Given this list of marker genes KAT2B, TFF3, SERPINA12, GCG, GNB3, SIK1, AKT2, PTPN2, AKT1, PPP4R3B, LEP, PDK3, IRS2, ZFP92, IRS1, ZNF692 (NCBI Gene Id 55657), IGF2, SESN2, TP53, KAT2A, ACADM, PPP1R3B, PGP, PRKACA, LEPR, RANBP2, NR0B1, MTCL2, MST1, SLC35B4, SIRT7, PPP4R3A, ZMPSTE24, SLC45A3, PMAIP1, LCMT1, FOXK1 (NCBI Gene Id 650798), PPP1R3G, ADIPOR1, RORC, INS, PRKAG2, USP7 (NCBI Gene Id 7874), CRY1, SORBS1, EP300, MIR107, PRKN, PTH, FOXO1, BCKDK, FBP1, C1QTNF3, PPARA, DDB1, ACACB, EPM2AIP1, PHKG2, FOXK2, MIR103A1, CLK2, GCK, SIRT1, NNMT, DYRK2, C1QTNF12, NLN, DGAT2, ADIPOQ, OGT, TCF7L2, MLYCD, PDK2, ADCY10, MIR210, IGF1, PPARGC1A, INSR, SDHAF3, NCOA2, GNMT, PRKAG1, PPP1R3E, PDK4, GPLD1, RORA, ARPP19, C1QTNF1, SIRT6, ERFE, PPP1CA, TIGAR, NR3C1, IGFBP3, DGKQ, NFE2L1, PHKA1, WDR5, SELENOS, HMGB1 (NCBI Gene Id 3146), ACTN3, IGFBP4, GSK3A, PRKAG3, PDK1 (pyruvate dehydrogenase kinase 1), here is a description of the gene set: species: Homo sapiens Human Gene Set: GOBP_REGULATION_OF_GLUCOSE_METABOLIC_PROCESS Any process that modulates the rate, frequency or extent of glucose metabolism. Glucose metabolic processes are the chemical reactions and pathways involving glucose, the aldohexose gluco-hexose.